The following is a description of a gene set: Meiosis Human Gene Set: REACTOME_MEIOSIS species: Homo sapiens, and this is the list of marker genes: H3C12, H4C5, H4C11, MSH4 (mutS homolog 4), H3C7, NBN, H3C1, SYNE2, H2BC13, RBBP8, RAD51C (NCBI Gene Id 5889), DMC1, H2BC3, TERF2, LMNA, H2BC1, H3-3B, SYCP3, H2BC12L, H3C14, SMC1A (NCBI Gene Id 8243), H2BC15, RAD50, H2AZ2, H4C3, H4C15, H4C13, H2AJ, H2BC9, H4C4, TERF2IP, H3C10, H2AC8, MLH1, H2AC18, H3-3A, BRCA2, H3C2, BLM, H3C8, H2AB1, SYCE3, SYCE2, RPA1, MLH3, ACD, H2AC14, FIGNL1, H4C2, RAD51, TERF1, MSH5, H2AX, H3C11, BRCA1, SYCP2, H2BC7, H4C16, H2BC26, SYCE1, PRDM9, ATM (ATM serine/threonine kinase), H2AC7, PSMC3IP, H2BC5, H2AC6, TINF2, MRE11, H3C3, H3C15, HSPA2, TOP3A (NCBI Gene Id 7156), H4C14 (NCBI Gene Id 8370), TEX15, H2BC14, H3-4, SYCP1, REC8 (REC8 meiotic recombination protein), SMC3, FKBP6, POT1, H2BC21, SMC1B (structural maintenance of chromosomes 1B), FIRRM, H2BC17, H4C9, H2AC20, H2BC11, SYNE1, UBE2I, H2AC4, DIDO1, RAD21, MND1, H3C6 (H3 clustered histone 6), RPA3, TEX12, H4C6, H4C1, SPO11, H2AC19 (H2A clustered histone 19), SUN1, ATR, H4C12, STAG3, STAG2, CDK2, H3C4, CDK4, STAG1, H2BC12, LMNB1, H3C13, H2BC4, H2BC6, H2BC10, H4C8, SUN2, H2BC8, RPA2